Given this list of marker genes Klf4, Ccl21f, Ccl28, Ccl21d, Ccl25, Ccl21b, Ccl21a, Ccl21e (C-C motif chemokine ligand 21E), Cxcl12, here is a description of the gene set: species: Mus musculus Any process that stops, prevents or reduces the frequency, rate or extent of leukocyte adhesion to vascular endothelial cell. Mouse Gene Set: GOBP_NEGATIVE_REGULATION_OF_LEUKOCYTE_ADHESION_TO_VASCULAR_ENDOTHELIAL_CELL